Given this list of marker genes Wdr62, Cdk2, Cdk5rap2, 4933427D14Rik, Ccp110, Cep76, Ppp1r35, Cep192, Plk4, Cep85, Cdc20b, Cep152, Wdr90, Nup62, Sass6, Cenpj, Rttn, Plk2, Cetn1, C2cd3, Cep44, Cntrob, Deup1, Cep72, Kat2a, Ofd1, Cep120, E2f4, Ccdc61, Cep135, Mdm1, Ccdc57, Trim37, Spice1, Poc1b, Kat2b (NCBI Gene Id 320956), Rbm14, Ccdc15, Cetn4, Stil, Npm1, Chmp2a (charged multivesicular body protein 2A), Alms1, Vps4b, D7Ertd443e, Poc5, Cep63, Ccdc78, Cep295, Cep295nl, Mcidas, Cetn2, here is a description of the gene set: Mouse Gene Set: GOBP_CENTRIOLE_ASSEMBLY A cellular process that results in the assembly of one or more centrioles. species: Mus musculus